The following is a description of a gene set: Any process that activates or increases the frequency, rate or extent of cytokine production involved in inflammatory response. species: Mus musculus Mouse Gene Set: GOBP_POSITIVE_REGULATION_OF_CYTOKINE_PRODUCTION_INVOLVED_IN_INFLAMMATORY_RESPONSE, and this is the list of marker genes: Appl1, Il17rc (NCBI Gene Id 76314), Mapk9, Il17ra, Prkca, Il17c, Myd88, Il17a, Hif1a, Kpna6, Tnf, Tlr6, Tlr3, Il17b, Pla2g3, Il17d, Cd6, Ticam1, Il17f, Tlr4, Clec7a, Stat3, Ankrd42, Il6, Card9, Mir324, Nod2, Gpsm3, Tarm1, Gbp5